Given this list of marker genes HPRT1, here is a description of the gene set: Reactome Pathway: Defective HPRT1 disrupts guanine and hypoxanthine salvage species: Homo sapiens Normally in humans, guanine and hypoxanthine can be salvaged by conversion to GMP and IMP, catalyzed by HPRT1 (hypoxanthine guanine phosphoribosyltransferase). In the absence of HPRT1 activity, however, accumulated guanine and hypoxanthine are catabolized by XDH (xanthine dehydrogenase / oxidase) to urate (Fu & Jinnah 2012). part of: Nucleotide salvage defects